The following is a description of a gene set: Genes down-regulated in comparison of dendritic cells (DC) before and 16 h after LPS (TLR4 agonist) stimulation. studied in species Homo sapiens from publication Ceppi M, Clavarino G, Gatti E, Schmidt EK, de Gassart A, Blankenship D, Ogola G, Banchereau J, Chaussabel D, Pierre P (PMID 19943945) Dendritic cells (DCs) are the sentinels of the mammalian immune system and they undergo a complex maturation process mediated by activation upon pathogen detection. Recent studies described the analysis of activated DCs by transcriptional profiling, but translation regulation was never taken in account. Therefore, the nature of the mRNAs being translated at various stages of DC activation was determined with the help of translational profiling, which is the sucrose gradient fractionation of polysomal-bound mRNAs combined to microarrays analysis. Total and polysomal-bound mRNA populations were compared in immature (0h) and LPS-stimulated (4h and 16h) human monocyte-derived DCs with the help of Affymetrix microarrays. Biostatistical analysis indicated that 296 mRNA molecules are translationally regulated during DC-activation. The most abundant biological process among the regulated mRNAs was protein biosynthesis, indicating the existence of a negative feedback loop regulating translation. Interestingly, a cluster of 17 ribosomal proteins were part of the regulated mRNAs, indicating that translation may be fine-tuned by particular components of the translational machinery. Our observations highlight the importance of translation regulation during the immune response, and may favour the identification of novel gene clusters or protein networks relevant for immunity. Our study also provides information on the possible absence of correlation between gene expression and real protein production in DCs. Human Gene Set: GSE14000_UNSTIM_VS_16H_LPS_DC_DN, and this is the list of marker genes: CD86, TDRD7, GABPB1, PGM3, TTYH2, PSMB2, BHLHE22, LDHA, CNP, LAMB3, NFKBIA, SS18, SLC38A5, H3C6, CFLAR, ATF7, DRAM1, CASP7, TRAF1, PSME1, GJB2, PIM1, SERF1A, TRAF3IP2, CEP135, BATF2, TEDC1, NXT2, PI4K2B, LILRA3, PRRG4, H3C10, IRF7, NFATC2IP, NFKBIZ, SAP18, ADTRP, PRPF3, PML, IL7, GRSF1, MICB, DCP1A, GOSR1, ADAR, COQ10B, NEK8, NABP1, WTAP, DNAAF1, TRIM26, ST3GAL5, DAPP1, LINC00847 (NCBI Gene Id 730780), HSD17B7, ZFTA, DTX3L, SMAD6, ETV3, IQCG, LY6E, TUBB3, ARL8B, PSMA2, PHLPP2, ARHGEF11, APOL2, CD274, NAMPT, C4orf46, AMD1, CHST7, BTG3, TRADD, CYRIA, ACSL1, TRIM21, ZFAS1, USP11, PIM3, CDK2, ZNF621, RUNX3, NOC3L, CR1L, MIER1, FSTL1, HMGCS1, SFT2D2, SMAP2, OSER1, GCH1, EBI3, RHOH, TUBB2A, TNFAIP2, NFE2L1, GTPBP1 (NCBI Gene Id 9567), PARP12, ECE1, SLFN12 (schlafen family member 12), ADAM19, SLC41A2, RIPK2, CDYL2, LSS, MBD2, FTH1, UBE2Z, EOLA2, SLC31A2 (NCBI Gene Id 1318), PMAIP1, TBC1D22B (NCBI Gene Id 55633), SLC25A28, GADD45B, IFI35, MVB12A, HSH2D, RAB30, RAB8B, MT1X, CYP27B1, RASSF4, MECP2, AGFG2, MSN, ALOX15B, TPST1, CLEC2D, RUFY3, TNFAIP1, STARD5 (NCBI Gene Id 80765), PARP9, KIAA0040, H2BC21, MT1HL1, FUT4, SAP30BP, CNOT4, HCP5, GMPR, MASTL, LYST, ELL2, MSC, TARS1, TNFAIP6, CMTR1, MRPL32, DNAI3, STAT5A, IRF8, PIWIL4, CIP2A, CKAP4, GPD2, EZH2, HILPDA, DHX58, SMG5, AIDA, WHAMM, PTK2B, OAS1, TBC1D13, C2orf49, NADK, IFIH1, RALGAPA2 (NCBI Gene Id 79617), DEPP1 (NCBI Gene Id 11067), IRF9, IRF2, GRAMD1A, SLAMF7, GRB10, CMPK2, PLAGL2, CDC73, RBX1, H2BC4, MFN1, SGPP2, JAK3, USP53, PPP1R15B, ANO7L1, IL15, NUB1, TRIP10, TNFRSF9, RABGAP1L, IFI44, MKLN1, NCK2, BST2, TNFSF10, STARD4, ENTPD7, MT2A (NCBI Gene Id 4502), STX17